The following is a description of a gene set: species: Mus musculus A process in which a protein is transported to, or maintained in, a location at an endoplasmic reticulum exit site. Mouse Gene Set: GOBP_PROTEIN_LOCALIZATION_TO_ENDOPLASMIC_RETICULUM_EXIT_SITE, and this is the list of marker genes: Bcap29, Mia3, Sec16b, Mia2, Sec16a, Bcap31, Lrrk2, Gbf1